The following is a description of a gene set: A vesicular organelle that forms on retraction fibers behind migrating cells and mediates the release of cytoplasmic contents during cell migration. Mouse Gene Set: GOCC_MIGRASOME species: Mus musculus, and this is the list of marker genes: Timm23, Tomm20, Pkd2, Tspan4 (NCBI Gene Id 64540), Pkd1, Epcip, Hspd1, Tspan9